The following is a description of a gene set: studied in species Homo sapiens from publication Cheok MH, Yang W, Pui CH, Downing JR, Cheng C, Naeve CW, Relling MV, Evans WE (PMID 12704389) To elucidate the genomics of cellular responses to cancer treatment, we analyzed the expression of over 9,600 human genes in acute lymphoblastic leukemia cells before and after in vivo treatment with methotrexate and mercaptopurine given alone or in combination. Based on changes in gene expression, we identified genes that accurately discriminated among the four treatments. Discriminating genes included those involved in apoptosis, mismatch repair, cell cycle control and stress response. Only 14% of genes that changed when these medications were given as single agents also changed when they were given together. These data indicate that lymphoid leukemia cells of different molecular subtypes share common pathways of genomic response to the same treatment, that changes in gene expression are treatment-specific and that gene expression can illuminate differences in cellular response to drug combinations versus single agents. Human Gene Set: CHEOK_RESPONSE_TO_MERCAPTOPURINE_AND_HD_MTX_DN Genes specifically down-regulated in pediatric acute lymphoblastic leukemia (ALL) patients by mercaptopurine and high dose methotrexate (HDMTX)., and this is the list of marker genes: KDM3B, SACS, UCHL3, YTHDC2, FCER2, PFDN6, TGFBR2, SART1 (NCBI Gene Id 9092), NPFF, SREBF2, SMCHD1, UBE2G1, SAP18, CENPC, CGRRF1, MPHOSPH9, NKG7, ABCA2, FAM216A, FAM234B, AHCY, AATF, CLTB, TGDS, SERPINE2